The following is a description of a gene set: The process in which a relatively unspecialized T cell acquires specialized features of a mature T follicular helper cell. Human Gene Set: GOBP_T_FOLLICULAR_HELPER_CELL_DIFFERENTIATION species: Homo sapiens, and this is the list of marker genes: IL21, FOXP1, RC3H1, IL6, ASCL2, ICOSLG, TBK1, ICOS, RC3H2, GPR183, PIK3R1